The following is a description of a gene set: Human Gene Set: REACTOME_APC_C_CDC20_MEDIATED_DEGRADATION_OF_CYCLIN_B APC/C:Cdc20 mediated degradation of Cyclin B species: Homo sapiens, and this is the list of marker genes: UBE2D1, UBC, ANAPC7, ANAPC16, ANAPC15, ANAPC1, CDC26, UBB, ANAPC10, UBA52, ANAPC5, UBE2E1, CDC20, CDK1, CCNB1, UBE2C, RPS27A, ANAPC4, UBE2S, CDC16, ANAPC11, CDC27, CDC23, ANAPC2